The following is a description of a gene set: studied in species Homo sapiens Human Gene Set: WP_NCRNAS_IN_WNT_SIGNALING_IN_HEPATOCELLULAR_CARCINOMA ncRNAs in Wnt signaling in hepatocellular carcinoma, and this is the list of marker genes: NKD2, FZD10, DVL2, SERPINF1, FRAT1, DANCR, CSNK2B, WNT3, RYK, SOST, CSNK2A3, FRAT2, DKK2, FZD7, CCND3, NLK, DKK4 (NCBI Gene Id 27121), KREMEN1, SOX7 (NCBI Gene Id 83595), NKD1, SFRP1, PLAU, WNT7B, SFRP5, SFRP2, FZD8, TCF7L2, WNT16, TCF7, FZD1 (NCBI Gene Id 8321), CHD8, WNT5B, FZD6, WNT6, MYC, LRP6, WNT11, WNT2B, MIR452, TCF7L1, WNT3A, JUN, LRP5, CSNK1E, NOTUM, DVL1, ELAVL1, MIR18A, CCND2, WNT10B, FZD3, FZD5, WNT2, CCND1, APC, CER1, CXXC4, SOX17, PORCN, CTNNBIP1, AXIN1 (NCBI Gene Id 8312), CSNK2A1, GSK3B, WIF1, SFRP4, FOSL1, DKK1, KLF4, CTNNB1, MTDH, SENP2, DVL3, CTBP1, CTBP2, ROR1, FZD9, WNT4, MIR214, WNT10A, CSNK1A1L (casein kinase 1 alpha 1 like), LEF1, WNT7A, FZD2, EZH2, ROR2, CSNK2A2, WNT1 (NCBI Gene Id 7471), WNT5A, CSNK1A1